The following is a description of a gene set: The process whereby a relatively unspecialized cell acquires the specialized features of an osteoblast, a mesodermal or neural crest cell that gives rise to bone. Human Gene Set: GOBP_OSTEOBLAST_DIFFERENTIATION studied in species Homo sapiens, and this is the list of marker genes: LRP5, NOTCH1, NBR1, MIR125B1, ALYREF, TNC, FBXO5, LOX, TAOK3, MIR205, SCUBE3, IL6, MIR29B1, TWSG1, MIR214, MRC2, DDX5, OSTN, ATRAID, MIR98, CTNNB1, H3-3A, BCAP29, ATP5F1B, ITGA11, RIOX1, NELL1, FIGNL1, PHB1, ID2, CTNNBIP1, ERFE, MIR93, LIMD1, TMEM53, CLEC5A, BGLAP, DNAI3 (NCBI Gene Id 126820), TWIST1, HSPE1, CEBPA, SUCO, RUNX2, SNRNP200, MIR138-1, HIRA (NCBI Gene Id 7290), VEGFA, SHOX2, MIR675, NPPC, ALPL, FASN, HEMGN, JUND (NCBI Gene Id 3727), JAG1, IL6R, RSL1D1, CCDC47, FAM20C, AXIN2, ID4, CYP24A1, MAPK11, SNAI2, AREG, CCN1, MIR203A, AMELX, HNRNPC, GLI3 (GLI family zinc finger 3), PTPRB (NCBI Gene Id 5787), FHL2, TMT1A, CEBPB (CCAAT enhancer binding protein beta), CRIM1, TWIST2, CAT, TCIRG1, SMAD5, MYBBP1A, TRPM4, RASSF2, MIR548D1, FFAR4, MIR140, CCL3, NF1, ACVR2B, ILK, SMAD3, NR1I3, BMP4, CDK6, FGF2, GDPD2, ADAR, PTCH1, FGF23, CBFB, MIR20A, HDAC7, LRRC17, REST, LRP3, NOG, BMPR2, MIR17, SNAI1, COL1A1, HOXA2, YAP1, TP63, VEGFC, SIRT7, LEF1, BMP2, TMEM64, MIR30B, SOX9, EPHA2, ASF1A, SFRP1 (NCBI Gene Id 6422), MIR9-1, MIR18A, SP7, DLX5, SPP1, CTHRC1, SEMA4D, ID3, SKI, NPNT, GTPBP4, IGFBP3, SHH, TENT5A, IFITM1, FGFR2, ACVR1, MIR20B, MIR24-1, MIR200C, SOX8, WNT11, GLI2, NOCT, HSD17B4, BMP7, PRKACA, UCMA (upper zone of growth plate and cartilage matrix associated), TP53INP2 (tumor protein p53 inducible nuclear protein 2), RORB, TNFAIP6, ACVR2A, SMAD4, SMAD9, TPM4, RANBP3L, FERMT2, ZHX3, WNT3A, IPO7, DNAJC13, RDH14, WNT7B, CITED1, RRAS2, BAMBI, FOSL2, IGFBP5, MEF2C, MAPK14, MIR100 (microRNA 100), GDF2, BMP3 (NCBI Gene Id 651), TNF, MIR320A, IBSP, TMEM119, RRBP1, MIR21, RSPO2, DHX9, MIR208A, AKT1, GSK3B (glycogen synthase kinase 3 beta), RBMX, PSMC2, SFRP2, WNT3, PTK2, MYOC, SEMA7A, MIR106A, TNN, CLTC, MIR3648-1, WNT4, PTHLH, FZD1, RPS15, MIR27A, MSX2, H3-3B (H3.3 histone B), GLI1, PTH1R, IL6ST, DDR2, SYNCRIP, BMPR1B, PTEN, CLIC1, PRMT3, FGF9, HNRNPU, WWTR1, FBL, CEBPD, IHH, FBN2, SOX2, PRKD1, LTF, VCAN, CHRD, MAP2K6, SMAD6, ACHE, WNT10B, ATF4, PENK, GABBR1, DHH, SUFU, PANX3, GDF10, MEN1, BMPR1A, COL6A1, TOB1, LGR4, SND1, BMP6, JUNB, PPP3CA, MIR210, GREM1, IGF1 (NCBI Gene Id 3479), SMOC1, CCN4, SATB2, CREB3L1, IGFBP2, MIR346, IARS1, ID1, WWOX, DDX21, SMO, IGF2 (NCBI Gene Id 492304), PPARG, SOX11, IFT80, HAND2, SMAD1, HGF, UFL1